The following is a description of a gene set: from publication Abbas AR, Baldwin D, Ma Y, Ouyang W, Gurney A, Martin F, Fong S, van Lookeren Campagne M, Godowski P, Williams PM, Chan AC, Clark HF (PMID 15789058) Human Gene Set: GSE22886_DAY1_VS_DAY7_MONOCYTE_IN_CULTURE_UP Genes up-regulated in comparison of monocytes cultured for 1 day versus those cultured for 7 days. studied in species Homo sapiens Immune cell-specific expression is one indication of the importance of a gene's role in the immune response. In order to identify such patterns, we set out to broadly profile gene expression in a variety of immune cells., and this is the list of marker genes: PMAIP1, IL2RA, CEP135, FOSL2, MAML1, RUNX1, STARD5, LPCAT1, ARHGAP45, PKIG, PIM2, TNFRSF4, KBTBD2, ATG2A, IL10, MCL1, DCP1A, RELB, UBR4, RHOG, EPS15L1, NBPF10 (NBPF member 10), MT1F, NR3C1, MARCKS, VNN3P, KLF6, CFP, ZC3H11A, IL23A, SERPINB7, HLX, IL3RA, IER3, LCP2 (NCBI Gene Id 3937), EIF4E2, GADD45B, ZC3H12A, UNC119, TOM1, RGL2, BASP1, IL32, MET, CD93, ARID3B, MAMLD1, CYP3A5, EHD1, JARID2, HBEGF, TXNL4B, LIMK2, CFLAR, SERPINB9, ANKHD1, PLK3, DUSP4, CLK4, HRH1, RSAD2, ZNF266, NINJ1, SLC16A7, ACSL5, TNIP2, IL6 (NCBI Gene Id 3569), NXF1, CCRL2, RBM5, BRD2 (bromodomain containing 2, NCBI Gene Id 9803), R3HCC1, ICAM1, CRLF2, USP34, GNA15, MTF1, PSMB4, S100A12, INHBA, NKX3-1, HIVEP2, IL12B, PTGS2, CYTH1, MMP1, CCR7, DAZAP2, KLHL21, TNIP3, MED13, ENTPD4, RIPK2, SLC25A37, SMAGP, SRC, PFKFB3, NBN, IRF7, EZH1, INPP5A, SNW1, SIK3 (NCBI Gene Id 80236), STK26, LAMP3, LRCH3, UPB1, UPP1, PDE4B, ETS2, IL24, ADGRE3, SERPINB8, TUT7 (terminal uridylyl transferase 7), FERMT2, KLHL28, TRAF1, NKTR, SLC2A6, LAPTM4B, NRF1, EPM2AIP1, HMGA2, MTSS1, ZHX2, ANPEP, IL15RA, PSMC1, IL36G, CDC42EP2 (NCBI Gene Id 10435), WDR45, BANP, IL6R, NFKBIA, TNFRSF9, IL16, SH3GL1, TNFAIP3, MIR22HG, NOTCH2NLA, SOD2, RHOH, RAP2C, C15orf39, CCL20, PPIF, ST3GAL1, HCAR3, ABTB2, TNFAIP8, PI3, ATP2B1, TRIM36, PTGIR, OSER1, GCH1, PPP1R15A, HLA-E, DNTTIP2, GON4L, IRAK3, OASL, PPP6R3, SLAMF1, PTX3 (pentraxin 3), LYN, FOXO3, RASGRP1, DDR1, DUSP22, AKAP13, ARID3A, RSRP1, NAMPT, MAP3K4, EMP3, APOL3, ING3, TNIP1, STAT4, TP53BP1, IL1A, DHX34, KIF3B, CCL1, PLAC8, SEC61G, ISG20, NDE1, TFE3, CCL5, NLRP3, TJAP1, TFPI2, NEDD4L, ZBTB43, EBI3, WNT5A